The following is a description of a gene set: Human Gene Set: WP_NOTCH1_REGULATION_OF_ENDOTHELIAL_CELL_CALCIFICATION studied in species Homo sapiens NOTCH1 regulation of endothelial cell calcification, and this is the list of marker genes: ALPL, JAG2, VEGFA, SAT1, JAG1, LPAR1, SOX6, PLAT, DLL4, DLL3, FGFR3, NOTCH1, MGP, CALU, GJA5, ITGA1, DLL1